The following is a description of a gene set: The chemical reactions and pathways involving vitamin D3, (3S,5Z,7E)-9,10-secocholesta-5,7,10(19)-trien-3-ol. Human Gene Set: GOBP_VITAMIN_D3_METABOLIC_PROCESS studied in species Homo sapiens, and this is the list of marker genes: CYP27B1, CYP2R1, CYP27A1, UGT1A4, FGFR1, CYP3A4, UGT1A3, CYP24A1